Given this list of marker genes CRY1, PLEKHM1, LAMP2, BMP4, BHLHE40, SMAD1, CTSK, SEMA4D, ATG3, JAK2, CTF1, SEMA3A, AKT1, BMPR2, ATG10, RORB, RUNX2, IL6, BMP3, ATG12, ATG4C (NCBI Gene Id 84938), IGF1, BMP5, ATG13, CHRD, PRKAA2, CALCA, SOST, NOTCH1, MAP1LC3B, BCL2, LEP, ATG101, NFATC1, SP7, MEPE, DKK1, SQSTM1, NPAS2, TRAF6, BMP2, ULK1, EFNB2, AMBRA1, NR1D2, BMP6, WNT5A, MAP1LC3A, TNFRSF11A, SERPINF1, DRAM2, SMAD5, RB1CC1, ARHGAP4, ATG7, FYCO1, VCP, TRAP1, CTHRC1 (collagen triple helix repeat containing 1), MTOR, WNT16, ATG16L1, CSF1, CLOCK, HMGB1, PIK3C3, TNFSF11, TGFB1 (NCBI Gene Id 7040), IL3, LRP5, BHLHE41, PER1, BMAL1, SMAD9, BECN1, PTH, SMAD4 (SMAD family member 4), TNFRSF11B, WNT10B, ATG5, here is a description of the gene set: Clock-controlled autophagy in bone metabolism studied in species Homo sapiens Human Gene Set: WP_CLOCKCONTROLLED_AUTOPHAGY_IN_BONE_METABOLISM